Given this list of marker genes Gm13238, Duxf1, Gm21083, Golga2, Gm8641, Lrrd1 (NCBI Gene Id 242838), Wdr47, Sfi1 (Sfi1 homolog, spindle assembly associated (yeast)), Gm7324, Abcc9, here is a description of the gene set: from publication Yevshin I, Sharipov R, Kolmykov S, Kondrakhin Y, Kolpakov F (PMID 30445619) Genes containing one or more binding sites for (Cbx1) in their promoter regions (TSS -1000,+100 bp) as identified by GTRD version 20.06 ChIP-seq harmonization. Mouse Gene Set: CBX1_TARGET_GENES species: Mus musculus